Given this list of marker genes DIAPH1, SLC27A4, TLE5, HEPACAM, RIMS4, SLAMF6, EP300, MTCL2, FICD, GRM5, DDN, MAMLD1, SHOX, GDPD4, TFCP2L1, TOB1, NRIP2, NECTIN1, FMNL3, ADCY5, ZFX, SAMD10, METTL21A, IGF2R, USP22, MLXIPL, RSPO4, ADPRHL1, DDHD1, RAB44, ZNF609, NCCRP1, ZNF253, PDLIM3, PLEKHS1, ZNF286B, HECTD3, PLXNC1, CTDSP1, CFAP44, PATE3, SLC39A13, PURB, ZSWIM6, NCOR2, COL11A2, HOXA1, CLN8, CYB5R2, C6orf89, GTPBP1, BACH2, BCAM, BRSK2, ATP1B4, HOMER1, CAPN6, EHD4, SLC16A14, ABHD13, ERG28, KRT4, ALG9, VPS13C (vacuolar protein sorting 13 homolog C), EIF4A1, WDR33, MSI2, TSPAN33, SOX6, NFIC, PDLIM7, ADAM19, LRRC27, MDGA1, SLC8A1, KAT7, ADI1, ATP6V0E1 (NCBI Gene Id 8992), SDK2, ZNF284, ZBTB39, INSYN2B, POU4F1, PMM2, ZNF286A, ZNF513, XPNPEP3, ZNF737, UPK1A, CLYBL, DOC2A, SSH3, PNKD, PDGFB, LDLRAD2, ZNF385A, SHISA7, SIRPB1, FTMT, SH3RF2, PHF8 (PHD finger protein 8), AMOT, ST3GAL1, NPPC, TNS4, PLAGL2, PDE4D, OS9, here is a description of the gene set: Genes predicted to be targets of miRBase v22 microRNA hsa-miR-6851-5p in miRDB v6.0 with MirTarget v4 prediction scores > 80 (high confidence targets). studied in species Homo sapiens from publication Chen Y, Wang X (PMID 31504780) Human Gene Set: MIR6851_5P